The following is a description of a gene set: The aim of this study is to survey global gene expression of total thymocytes from wild-type mice and Atg16l1 mutant (hypomorph) mice. studied in species Homo sapiens Genes down-regulated in tymocytes: mutant (hypomorph) ATG16L1 versus wildtype. Human Gene Set: GSE12707_AT16L1_HYPOMORPH_VS_WT_THYMUS_DN from publication Cadwell K, Liu JY, Brown SL, Miyoshi H, Loh J, Lennerz JK, Kishi C, Kc W, Carrero JA, Hunt S, Stone CD, Brunt EM, Xavier RJ, Sleckman BP, Li E, Mizushima N, Stappenbeck TS, Virgin HW 4th (PMID 18849966), and this is the list of marker genes: PHACTR3 (phosphatase and actin regulator 3), RPL7A, MIR202, DBH, VTCN1, RUNX3, PARVA, ZBTB8B, RRAGD, TMEM45B, TMPRSS5, SLC35E1 (NCBI Gene Id 79939), WSB2, SYNE2, RHBG, CTRL, TRIM45, TMEM132E, GALNT18, HOMER2, UCP2, GAMT, SYT5, TMEM125 (NCBI Gene Id 128218), C1QC, MIR216A, TTC9, BEGAIN, GARIN1B, SLC45A2, SRY, PLCL2, LMLN (NCBI Gene Id 89782), GPR20, TRAPPC5, TNNI2, FBXL22, TBC1D9B, ZHX2, VAMP2, NPW, FAM170B, FAM168B, NRK, GNG4, FMNL2, DDR1, HCFC1, AOAH, TMCO2, IGLL1, LNX2, SETD1B, GRSF1, GGCX, UBQLN1, CTNND1, SIPA1L3, DPEP3, CDHR5, RHOG, ZGLP1, DAGLB, HNRNPUL1, TBX4, CCDC148, ERN2, AGTR1, GEMIN5, ROM1, CACNA1F, RNF222, ITPRIPL2, CHRDL1, PLCD1, MBOAT4, DSE, SV2B, MIRLET7B, PDE3A, NAF1 (nuclear assembly factor 1 ribonucleoprotein), ZIC2, CHRNE, FAS, MIR181C, CLRN3, FAHD1, SETD1A, DSG4, ATP6V0C, GNS, MIXL1, PPP1R37, PRSS42P, GRIK4, PROC, TTC38, TSPAN1, MYMK, F10, TBC1D8, NIPAL4, ALPK2, KCNQ4, EPN1, ABRA, SS18L1, FOXD3, DEAF1, MIR222, STAT3, TRIM42, NR1H3, ASPG, CACNB3, RASL11A, KRTAP7-1, PLCD3, NOL6 (NCBI Gene Id 65083), STX3, CTF1, MRO, SERTAD2, PTPRU, MUC4, NUB1, PHF2, TRAM2, PRAME, PRLH